Given this list of marker genes Tjp1, Snai1, Twist1, Cdh4, Cdh1, Cdh3, Hnrnpab, Snai3, Trim28, here is a description of the gene set: from publication Nadella KS, Jones GN, Trimboli A, Stratakis CA, Leone G, Kirschner LS (PMID 18413734) Mouse Gene Set: NADELLA_PRKAR1A_TARGETS_UP species: Mus musculus Epithelial and mesenchymal markers up-regulated in MEF cells (embryonic fibroblasts) after knockout of PRKAR1A. Dysregulation of protein kinase A (PKA) activity, caused by loss of function mutations in PRKAR1A, is known to induce tumor formation in the inherited tumor syndrome Carney complex (CNC) and is also associated with sporadic tumors of the thyroid and adrenal. We have previously shown that Prkar1a(+/-) mice develop schwannomas reminiscent of those seen in CNC and that similar tumors are observed in tissue-specific knockouts (KO) of Prkar1a targeted to the neural crest. Within these tumors, we have previously described the presence of epithelial islands, although the nature of these structures was unclear. In this article, we report that these epithelial structures are derived from KO cells originating in the neural crest. Analysis of the mesenchymal marker vimentin revealed that this protein was markedly down-regulated not only from the epithelial islands, but also from the tumor as a whole, consistent with mesenchymal-to-epithelial transition (MET). In vitro, Prkar1a null primary mouse embryonic fibroblasts, which display constitutive PKA signaling, also showed evidence for MET, with a loss of vimentin and up-regulation of the epithelial marker E-cadherin. Reduction of vimentin protein occurred at the posttranslational level and was rescued by proteasomal inhibition. Finally, this down-regulation of vimentin was recapitulated in the adrenal nodules of CNC patients, confirming an unexpected and previously unrecognized role for PKA in MET.